Given this list of marker genes MMP12, CST3, LEP, MIR181B1, CTSL, HIF1A, CELA1, here is a description of the gene set: Human Gene Set: GOBP_ELASTIN_METABOLIC_PROCESS species: Homo sapiens The chemical reactions and pathways involving elastin, a glycoprotein which is randomly coiled and crosslinked to form elastic fibers that are found in connective tissue.